The following is a description of a gene set: Mouse Gene Set: MIR_323_3P Genes predicted to be targets of miRBase v22 microRNA mmu_miR_323_3p in miRDB v6.0 with MirTarget v4 prediction scores > 80 (high confidence targets). species: Mus musculus from publication Chen Y, Wang X (PMID 31504780), and this is the list of marker genes: D1Pas1, Sirt1, Phf20l1, Sema3d, Ppp4r2, Mitf, Trappc10, Rps6ka6, Ing3 (NCBI Gene Id 71777), Klf11 (Kruppel-like transcription factor 11), Rhot1, Mapk6, Armcx5, St8sia1, Iqch, Med12l, Ogt, Azin1, Nipbl (NIPBL cohesin loading factor), Rassf2, Aftph, Cldn8, 5730455P16Rik, Ikzf2, Tlcd4, Cdc27, Sim1, Pkn2, Rnf103, Fam216a, Htr2c, Relch, Pbx3 (NCBI Gene Id 18516), Galr1, Lrrn1, Ulk2, App, Plppr5, Zfp105, Tmeff2, Qrfpr, Kcnb1, Acsl6, Mab21l1, Dnajb6, Zfp7, Wdr44, Trps1 (transcriptional repressor GATA binding 1), Fam227a, Epc1, Ostm1, Pak5, Slc25a16, Usp42, Psmc6, Pus10, Thoc1, Slc13a1 (solute carrier family 13 (sodium/sulfate symporters), member 1), Cavin2, Zpbp, Ankib1, Odf2l, Calb1, Atp1b1, Fbxo8, Pcdh7, Mtmr2, Mtch2, Tgfa, AI597479, Hmgcs1, Cyp20a1, Ppp1r14c, Dnajc6, Commd8, Cldn1, Glrb, Clock, Ensa, Ppfibp1, Fam13a, Pappa2, Spty2d1, Sh3gl3, Rbm27, Zfp148, Adipor1, Macrod2, Wdr45, Ptpn9, Osbpl8, Fnip1, Arid1b, Kras, Ewsr1, Sorcs1, Pum1, Lmbrd1, Cep70, Tbpl2, Rc3h2, Xkr4, Prpf4b, Mctp1 (NCBI Gene Id 78771), Crisp4, Lmo7, Tnrc6b, Ube2q1 (ubiquitin-conjugating enzyme E2Q family member 1), Lpar4, Prkra, Sema6a, Rftn2 (NCBI Gene Id 74013), Ubxn2a, Mat2b, Zfp281, Kalrn (NCBI Gene Id 72378), Prr23a3, Tom1l1, Ttc39b, Cnot6, Cks2, Brinp1, Hells, Sorbs1, Hipk1, Wnt5a, Ifrd1, Gnai1, Enox1, Fndc3a, Appl1, Epha5, Gja1, Srek1ip1, Rock2, Ikzf5, 1110032F04Rik, Ppm1b, G3bp2, Fmr1, Golim4, Raph1, Fndc3b, Asah1, Pcdh8, Map3k2, Txnl1, Itpr3, Eif1, Lrrc8e, Mysm1, Pou4f2, Psme3, Stk39, Tet2, Ubap2, Arf1, Ptpn2, Eed, Kitl, Tbl1xr1, Gnb4, Jmy, Sgk1, Atp11a, Ctla2a, Thsd7a, Dhx9, Pde4b, Slc12a8, Chmp5, Gad1